The following is a description of a gene set: The chemical reactions and pathways involving 9-cis-retinoic acid, a metabolically active vitamin A derivative. studied in species Mus musculus Mouse Gene Set: GOBP_9_CIS_RETINOIC_ACID_METABOLIC_PROCESS, and this is the list of marker genes: Aldh8a1, Aldh1a1, Dhrs9, Cyp1a1, Rdh16, Rdh9, Aldh1a2